The following is a description of a gene set: Human Gene Set: REACTOME_TYSND1_CLEAVES_PEROXISOMAL_PROTEINS species: Homo sapiens TYSND1 cleaves peroxisomal proteins, and this is the list of marker genes: PHYH, HSD17B4, TYSND1, SCP2 (sterol carrier protein 2), AGPS, ACAA1, ACOX1